Given this list of marker genes Kpnb1, Kpna1 (NCBI Gene Id 16646), Ran, Snupn, Kpna6, Kpna4, Kpna2rt, Kpna3, Kpna7, Xpo5, Mybbp1a, Kpna2, here is a description of the gene set: Any complex that acts to move proteins or RNAs into or out of the nucleus through nuclear pores. Mouse Gene Set: GOCC_NUCLEOCYTOPLASMIC_TRANSPORT_COMPLEX studied in species Mus musculus